Given this list of marker genes S100A11, EMP3, PELI1, SIRPAP1, HLA-DPA1, IL10RA, WIPF1, IFI16, BCL3, CYBA, TGM2, EZR, PTGER4 (NCBI Gene Id 5734), CELF2, ICAM1, SEL1L3, SIRPA, DAB2, HLA-DPB1, ARL4C, STAT1, CLEC2B, LAPTM5, THEMIS2, IFI44, HMGN3, RAB31, ARHGDIB (NCBI Gene Id 397), here is a description of the gene set: Human Gene Set: BOYAULT_LIVER_CANCER_SUBCLASS_G5_DN Hepatocellular carcinomas (HCCs) are a heterogeneous group of tumors that differ in risk factors and genetic alterations. We further investigated transcriptome-genotype-phenotype correlations in HCC. Global transcriptome analyses were performed on 57 HCCs and 3 hepatocellular adenomas and validated by quantitative RT-PCR using 63 additional HCCs. We determined loss of heterozygosity, gene mutations, promoter methylation of CDH1 and CDKN2A, and HBV DNA copy number for each tumor. Unsupervised transcriptome analysis identified 6 robust subgroups of HCC (G1-G6) associated with clinical and genetic characteristics. G1 tumors were associated with low copy number of HBV and overexpression of genes expressed in fetal liver and controlled by parental imprinting. G2 included HCCs infected with a high copy number of HBV and mutations in PIK3CA and TP53. In these first groups, we detected specific activation of the AKT pathway. G3 tumors were typified by mutation of TP53 and overexpression of genes controlling the cell cycle. G4 was a heterogeneous subgroup of tumors including TCF1-mutated hepatocellular adenomas and carcinomas. G5 and G6 were strongly related to beta-catenin mutations that lead to Wnt pathway activation; in particular, G6 tumors were characterized by satellite nodules, higher activation of the Wnt pathway, and E-cadherin underexpression. CONCLUSION: These results have furthered our understanding of the genetic diversity of human HCC and have provided specific identifiers for classifying tumors. In addition, our classification has potential therapeutic implications because 50% of the tumors were related to WNT or AKT pathway activation, which potentially could be targeted by specific inhibiting therapies. Down-regulated genes in hepatocellular carcinoma (HCC) subclass G5, defined by unsupervised clustering. species: Homo sapiens from publication Boyault S, Rickman DS, de Reyniès A, Balabaud C, Rebouissou S, Jeannot E, Hérault A, Saric J, Belghiti J, Franco D, Bioulac-Sage P, Laurent-Puig P, Zucman-Rossi J (PMID 17187432)